The following is a description of a gene set: from publication Elvidge GP, Glenny L, Appelhoff RJ, Ratcliffe PJ, Ragoussis J, Gleadle JM (PMID 16565084) Genes down-regulated in MCF7 cells (breast cancer) treated with hypoxia mimetic DMOG. Studies of gene regulation by oxygen have revealed novel signal pathways that regulate the hypoxia-inducible factor (HIF) transcriptional system through post-translational hydroxylation of specific prolyl and asparaginyl residues in HIF-alpha subunits. These oxygen-sensitive modifications are catalyzed by members of the 2-oxoglutarate (2-OG) dioxygenase family (PHD1, PHD2, PHD3, and FIH-1), raising an important question regarding the extent of involvement of these and other enzymes of the same family in directing the global changes in gene expression that are induced by hypoxia. To address this, we compared patterns of gene expression induced by hypoxia and by a nonspecific 2-OG-dependent dioxygenase inhibitor, dimethyloxalylglycine (DMOG), among a set of 22,000 transcripts, by microarray analysis of MCF7 cells. By using short interfering RNA-based suppression of HIF-alpha subunits, we also compared responses that were dependent on, or independent of, the HIF system. Results revealed striking concordance between patterns of gene expression induced by hypoxia and by DMOG, indicating the central involvement of 2-OG-dependent dioxygenases in oxygen-regulated gene expression. Many of these responses were suppressed by short interfering RNAs directed against HIF-1alpha and HIF-2alpha, with HIF-1alpha suppression manifesting substantially greater effects than HIF-2alpha suppression, supporting the importance of HIF pathways. Nevertheless, the definition of genes regulated by both hypoxia and DMOG, but not HIF, distinguished other pathways most likely involving the action of 2-OG-dependent dioxygenases on non-HIF substrates. species: Homo sapiens Human Gene Set: ELVIDGE_HYPOXIA_BY_DMOG_DN, and this is the list of marker genes: JAK2, PSME3, IDE, ESR1, SPAG1, IDH3A, SLC25A44, RPP25, ATP6V0A2, ALDH4A1, TAF9B, ADAT1, ATP2A3, NAPA, CALM1, RIOX1, CENPN, ADGRG1, SLC35C1, PYCR3, ZMPSTE24, SLC24A3, SOCS2, SRM, NUP98, ZGPAT, CTPS1, GABBR2, SRSF1, CCND3 (cyclin D3), CORO1A, POLR3K, HSPA4, PDZK1, SDF2L1, RET, AOX1, PIK3R3 (phosphoinositide-3-kinase regulatory subunit 3), SLC5A6, DOLK, SLCO3A1, TIGAR, SPDEF, CEBPA, SOBP, ODC1, ADORA1, URB2, LPCAT3, NDUFS6, SLC29A1, ACOT7, RPP40, TOR3A, CXCL12, WDR77, PUS1, GDPD3, GPATCH2